The following is a description of a gene set: Presence of iris pigment epithelium on the anterior surface of the iris. Human Gene Set: HP_UVEAL_ECTROPION species: Homo sapiens Uveal ectropion, and this is the list of marker genes: ZEB1 (zinc finger E-box binding homeobox 1), COL8A2, VSX1, LAMB2, GRHL2 (NCBI Gene Id 79977), OVOL2, CPAMD8